Given this list of marker genes DMP1, ART3, BMPER, DSC1, LCT, WNT1, SAA4, SYT11, FOXH1, MBL1P, PTGDR2, ASTN1, MATN4, NMBR, NLE1, MAP3K14, ZNF208, ATRNL1, RAB3A, AKR1D1, CHRNA1, CTRB1, TRPC3, ZNF264, NTN3, FOXN2, NACAD (NCBI Gene Id 23148), AP4E1, GRM8, CDKN2B, MLLT3, RFPL1S, GABRA6, EPHA7, BHMT, OPHN1, ODF2, PDE9A, BAAT, ZFY, ATP2A1, MTRF1L, PRM2, PRORP, RPGRIP1L, VIPR2, XPNPEP2, CRYBB3, SPAG8, CYP4F11, VPS41, OPRPN, KRT37, OPN1SW, SERPINC1, CBLIF, IFNA4, SEC14L2, TNNT2, SLITRK2, ZNF239, MPHOSPH8, SCN5A, KCNH1, NPY5R, RASGRF1, CYP1A2, LCAT, MYBPH, TCF15, CD3G, TNFSF11 (TNF superfamily member 11, NCBI Gene Id 8600), HCG4, C1orf21, MYCNOS, AVPR1A, GPR176 (G protein-coupled receptor 176), NEU3, CST5 (NCBI Gene Id 1473), IRGC, BRDT (NCBI Gene Id 676), IL18RAP, PHKG2, RBM17, MYH7, RFX1, DDN, HOXD9, RPGRIP1, CUL3, ANGPTL7 (angiopoietin like 7), KIF1A, LRRTM2, TEKT2, CA5A, HIPK2, ZNF154, ADAM7, COX10, SOX3, AVP, GK2, FSTL4, PDE6C, BNC1, EIF2B1, DOC2A, here is a description of the gene set: Neighborhood of WNT1 wingless-type MMTV integration site family, member 1 in the MORF expression compendium species: Homo sapiens Neighborhood of WNT1 Human Gene Set: MORF_WNT1